Given this list of marker genes Adrb1, Ppp3cc, Ccl12, Ppp3cb, Pdgfb, Ms4a1, Gcg, Ppp3r2, Agtr1a, Strit1, Trpv2, Cxcl12, P2rx1, Pdgfrb, Crh, Trpv3, Dspp, Atp2c2, Serpine1, Ppp3r1, Lgals3, Ppp3ca, Akap5, Ucn, Grm6, P2rx5 (purinergic receptor P2X, ligand-gated ion channel, 5), Casr, Stc1, Cask, Cxcr4, Isl1, Adrb2, here is a description of the gene set: Mouse Gene Set: GOBP_POSITIVE_REGULATION_OF_CALCIUM_ION_IMPORT species: Mus musculus Any process that increases the rate, frequency, or extent of the directed movement of calcium ions into a cell or organelle.